Given this list of marker genes GRID2IP, SUSD4, CNTN6, P2RX6, CTNNA2, PPP3R1, GRIA3, CBLN1, CBLN3, STXBP1, KCNJ9, CALB2, SPTBN2, ATP2B3, SLC6A9, CADPS2, GNB5, SLC16A7, UNC13C, GNAO1, TMEM240, GPM6A, KCNJ3, GRID2, here is a description of the gene set: species: Homo sapiens Human Gene Set: GOCC_PARALLEL_FIBER_TO_PURKINJE_CELL_SYNAPSE An excitatory synapse formed by the parallel fibers of granule cells synapsing onto the dendrites of Purkinje cells.